The following is a description of a gene set: species: Mus musculus electronically inferred by orthology from the curated human pathway part of: Netrin-1 signaling This event has been computationally inferred from an event that has been demonstrated in another species.<p>The inference is based on the homology mapping from PANTHER. Briefly, reactions for which all involved PhysicalEntities (in input, output and catalyst) have a mapped orthologue/paralogue (for complexes at least 75% of components must have a mapping) are inferred to the other species. Reactome Pathway: DCC mediated attractive signaling, and this is the list of marker genes: Fyn, Cdc42, Ptk2